The following is a description of a gene set: Human Gene Set: GOBP_INTRACELLULAR_TRANSPORT The directed movement of substances within a cell. studied in species Homo sapiens, and this is the list of marker genes: OSBP, TMED2, DOP1B, TUBA1B, PARK7, SEC63, LEPROT, KLC3, AP1G1, RAB1B, TBC1D10A, KIF28P, RILPL1, AHCYL1, ABRA, HGSNAT, SNX10, AP1S2, NOTCH1, DDX25, PPP6C, AHCTF1, BAG3, PKIG, EPS15L1, AP3B1, DTNBP1, PLA2G4E, RSRC1, IFT74, VIPAS39, PKD1, RGPD5, XPO5, ABCA12, HIF1A, SEC16B, STX1A, STX7, RUFY1, ACAP2, UPF1, NMD3, MIA3, TRAM1L1, REPS1, RAB8B, HPS1, MIA2, ZC3H11C, CSNK1D, NEFL, CCDC88C, BLOC1S2, MAPK14, FUZ, TRIM37, TNPO3, RILP, NDFIP2, HDAC6, HSPA9, TIMM10, CMTM6, CCDC186, MVB12A, OPA1, TRARG1, TOMM40, SNX18, DDX39A, VPS18, BLOC1S5, TNPO2, APPL1, E2F3, ATP2A3, ARFIP2, MDM2, ING1, SLC17A9, PCID2, TSG101, TOMM20, PPP3R1 (NCBI Gene Id 5534), REEP6, GRPEL1, ITSN2, ANKRD27, GAK, RAPGEF3, RGPD1, PRKAG1, KPNA2, SLC25A20, RAB11A, KIF20B, IL33, CRYAA, MICALL2, KIF1B (kinesin family member 1B), CRYAB, ATF2, YWHAB, ARL5A, SEC24D, CUL3, TMEM97, NUP153, KIF5B, NEDD4, STRADB, CRACR2A, CD74, TRAM1, ROMO1, STX10, SIRT6 (NCBI Gene Id 51548), SORCS2, SEC23B, MAPK15, PHETA1, RAB5B, TMCO6, MAP6D1, GLE1, TMEM53, SCG5, UFM1, SEM1, LAMP2, PEX7, FMN2, COPA, DOP1A, NME7 (NME/NM23 family member 7), MAGOH, SEC61G (SEC61 translocon subunit gamma), RHOB, WASH3P, XPOT, BICDL2, CTDSPL2, ARHGAP44, RIMS2, ATP9A, BRSK2, SCFD1, PRP4K (pre-mRNA processing factor kinase PRP4K), P4HB, TIMM21, SPAG17, WDR19, MAPT, SVIP (small VCP interacting protein), RNF126, BET1L, NXF3, FAM76B, GGA1, COPG2, LAMTOR1, STBD1, C12orf50, PHAX, STK4, IFT70A, RAB14, SEC24B, NCBP1, SCFD2, KCNQ3, CLTC, NDUFA13, MIR17, ASPH, CLEC16A, CLTCL1, HGS, VPS37C, CCDC38, RGPD4, SUFU, OAZ1, PTPN14, MX2, LMAN2L, BLOC1S1, TBC1D14, GRAMD1C, ATP6AP1 (ATPase H+ transporting accessory protein 1), OSBPL2, PLA2G3, TRAK2, TIMM17B, MYO19, PEX10, UBAC2, DTX3L, EHD3, NAPG, PLEKHF2, TENM1, BORCS8, B3GAT3, SMAD3, SNX1, PHETA2, TMCC1, DRD1, IFT20, YKT6 (YKT6 v-SNARE homolog), TERT, ARHGAP8, KIF3B, DENND10, SEC22B, IWS1, CLBA1, LIPA, PPP1CC, BECN1, RAB12, SNX12, ANKFY1, RAB28, AP1AR, RIOK2, ATP2A2, LCA5L, CPSF6, AP1M1, SNX11, EIF6, NAPB, PIK3R2, CHMP4C, TOMM22, AP5B1, SNX7, BARD1, EPS15, ZC3H11A, PEX3, SNX8, IFT56, STXBP2, PIP4K2A, STX19, EIF4ENIF1, SSX2IP, MIR185, TRAPPC6B, AP4B1, TRAPPC8, IFT80, NUP35, NETO1, SLC66A2, HERC2, ERGIC1, HTATIP2, RANBP3L, NPM1, FHIP1B, UPF2, WDPCP, MICALL1, UBE2G2, CITED1, AKIRIN2, RAB3GAP2, RBM22, STX16, TIMM8A, VPS37D, HYOU1, NGFR, WIPF3, SCAP, RASGRP1, ATP13A2, SYTL3, NTN1, XPO1, TRAPPC6A, NUP54, SNX2, LMF1, TMEM50B, CSE1L, AFTPH, GRIP1, ARL4D, ANXA8L1, THOC3, TMED6, RUFY3, BTBD8, NAPA, TBC1D23, MAP1A, CTTN, POM121L2, WAS, MYO5B, ZIC1, SRP54, ARFRP1, RHBDD1, EHD4, UMOD, PEX1, ANP32B, CLU, SNX30, BECN2, RGPD3, TTC21A, BIN1, TRIM23, PIKFYVE, MAP1B, KPNA5, IFT25, NOL6, CES1, ANKRD50, MREG, SORT1 (NCBI Gene Id 6272), VPS26B, BMP4, RAB7A, ARL5C, RAN, CHMP6, RAB2A (RAB2A, member RAS oncogene family), GRIPAP1, AP3M2, SCARB2 (scavenger receptor class B member 2), SPG7, RAB9B, HEATR5B, SPG11, GOLT1B, TMEM106B (NCBI Gene Id 54664), BLOC1S6, TMEM129, RAMP2, PIK3R1, TECPR2, RAB6C, NUP62CL, CNIH4, IPO4, NEFH, TRAPPC13, RAB4B, SMG5, SPIRE2, NFKBIA, VAMP3, RFFL, ATL3, RNF139, POM121B, MYO6, FABP3, KIF3A, RAB6D, VPS35L, JAK2, KPNB1, DENND1A, RELCH, RAB31, MTX1 (NCBI Gene Id 4580), THOC6, VPS13B, SEC22C, ARSB, DENND2A, RAB22A, TSNARE1 (NCBI Gene Id 203062), COG7, RAB20, TUBB, INPP5F, TMEM41B, GSK3B, BBS12, TOMM6, STEEP1, VAMP4 (NCBI Gene Id 8674), MYO7A, SAR1B, STAM, SEC16A, VTI1A, EIF2D, WASF1, CPT1A, LEP, AP1S3, CABP1, SYK, APBA1, AGAP2, SEC31A, SYT7, OAZ3, HOOK3, UBE2J1, DNAJC19, ENY2, CTAGE15, KIF13A, STAU2, CDH1, RAB5A, UBE2I, SNX31, SYTL2, RAB41, RAB35, SYNE2, WDR11, RAB11FIP3, TMED5, FAM53A, CTSA, SLN, CREB3L2, HPS4, RBM15B, STX4, MYO10, RAMP3 (receptor activity modifying protein 3), DERL3, ARL6, MAPK8IP3, CRY2, CDKN1B, VPS45, CLN5, BAIAP3, AP2S1, KPNA7, STARD4, NXT1, NUP107, AKT1, PPM1A, SCYL2, GBF1, SERAC1, KIFC2, MED1, RGPD2, AKAP8L, NUTF2 (NCBI Gene Id 10204), GAS6, SGPP1, TIMM9, SOD1, RANGRF, CHP2, LRP1, ARL3, AGBL4, USE1, RPGR, YIF1A, HOOK1, BORCS7, USP7, NUP93, MVB12B, TIMM44, GOPC, ARFGAP3, KIF1C, SEH1L, TFG, ATG5, NUP62, FLOT2, DERL2, VPS11, CAMSAP3, TOMM7, HSPB1, LRRK2, DDX39B, CD36, FERMT1, DYNC1LI1, MAGEL2, NEMF, RABL3, TAP2, AP3M1, COPZ2, LMNB1, RABGGTB, NHERF1, SFN (NCBI Gene Id 2810), ARL5B, IFT140, SYNDIG1, FEZ1, CD63, TRIM46, SPAST, TUBA1A, F8A2 (coagulation factor VIII associated 2), SPRN, PIK3R4, AGK, DENND3, IFT70B, PCSK9, HIKESHI, UBAP1, UBXN6, DYNLT2B, ENTR1, CHMP7, OAZ2, SSNA1, TOMM5, AP5M1, PICALM, LONP2, BET1, TRAPPC4, TMED7, CHP1, MAP6, ARL8A, SDCBP2 (syndecan binding protein 2), MAP2, DYNC1I2, MIR27B, HSP90AA1, CCDC88B, SNX9, VAMP7, TMED10, HNRNPA2B1, YTHDC1, TBC1D13, F8A1, SRC, CDKN2A, CHMP1A, SNX13, COG3, ANP32CP, SPAG9, RAB10 (RAB10, member RAS oncogene family), RHOT2, ERC1, LDLR, SGSM2, IRGM, NAGPA, NUP210, ARHGAP21, SMO, RGPD8, ACTN4, CHMP3, DYNC2LI1, ACTR10 (actin related protein 10), PEX16 (peroxisomal biogenesis factor 16), AP5S1, WHAMM (NCBI Gene Id 123720), TBC1D10B, ARL11, PRKCD, ACTR2, PRR5L, NUP88, RANBP2, VPS28, SNF8, TBC1D17 (TBC1 domain family member 17), KIF17, NUS1, IFT22, TRAPPC11, CLTA, STAR, LRRC7, NDE1, UFD1, HEATR5A, PLEKHA8, RBM4, CLUAP1, MTCH1, ABCD1, SYT4, TMED3, INTU, SCP2, PLEKHM1, THOC2, FNBP1L, LARGE1, ASPSCR1, NUP214, RIC1, TSPO2, AP4E1, MAP2K2, SYS1, MAPK3, HSPA12A, TRAPPC9, VPS50, RANBP3, NUP42, KIF16B, APPL2, CORO1A, MDN1, LAPTM5, CILK1, PREPL, KIF5A, KIFBP (kinesin family binding protein), ECT2, PCDHGA3, VPS33B, TERF2, NOP9, ARMCX3, MAP1LC3C, SLC48A1, NPLOC4, STXBP3, WDR81, LRPPRC, PLN, VCP, WASHC4, ADRB2, RIMS1 (regulating synaptic membrane exocytosis 1), RAB18, LMNB2, AGFG1, MYLK2, CCDC91, CRYZL2P-SEC16B, MAP1S, PEX5, ITSN1, SH3TC2, TRIM27 (tripartite motif containing 27), STX17, LMTK2, VPS41, SPTBN5, NUP205, VPS36, UBE2O, LYST (lysosomal trafficking regulator), ABCA2, KLHL12, TXNIP, BORCS5, PLEKHJ1, EHD2, PLEKHA3, CSPG5, SNX32, ABCG1, LZTS2, MYO1C, USO1, AP3B2, MPPE1, WDR91, COPZ1, SETD2, GOSR1, NUMA1, PML, CDC42, PREB, ARL8B, MGRN1, ZFYVE9, EIF4E, CCHCR1, AFG2B, BICD2, BICDL1, TMEM30B, MON1A, EDEM1, IFT46, BORCS6 (BLOC-1 related complex subunit 6), YIF1B, TMEM201, FBXO22, DENND1C (DENN domain containing 1C), GRAMD1B, ANKLE1, TMEM30A, BBS5, TLK1, VPS26C, TMEM87B, MYH10, SRSF3, RABL2B, AKAP5, CCDC22, C2CD5, THOC7, ERLEC1, AUP1, EHD1, RAB43 (NCBI Gene Id 339122), DCLK1, SYTL1, PEX2, SHH, SEC23IP, C9orf72, SIX2, BICD1, MRLN, EP300, WASHC2A, GGA2, ATG16L1, DST, EEA1, SEC24A, FMR1, ARF3, AP2B1, TMED9, IFT52, C17orf75, STRIT1, MAGOHB (NCBI Gene Id 55110), STK11, SNX6, NDRG4, PEX6, CEP120, CTAGE4, SEC13 (NCBI Gene Id 6396), CWH43, RHOBTB3, TANC2, THOC5, IPO13 (importin 13), LAMP1, SRSF10, RABL2A, ALMS1, PABPN1, GLI3, IFT43 (intraflagellar transport 43), VPS8, SYBU, ZC3H11B, RAB27B, MTMR2, RAB1A, GCC2, MTMR4, STK3 (serine/threonine kinase 3), ATXN1, RIPOR1, RAB24, YWHAH, KPNA1, DNAJC27, ANXA8, RAB32, BLTP3B, ERP29 (endoplasmic reticulum protein 29), TRAPPC5, SIRT7, ZMPSTE24, DHX9, ALS2CL, NF1, DCTN1, TIMM13, TIMM10B, ARL17B, NR4A1, DAB2, SLU7, VPS53, RAB11FIP4, PHB2, CHMP2B, SYTL5, NF2 (NF2, moesin-ezrin-radixin like (MERLIN) tumor suppressor), STAT3, JUP, DERL1, IGF2R, STX2, MAVS, LYSET, NXT2, RCSD1 (NCBI Gene Id 92241), DLG2, AP2M1, HNRNPA1, RAB7B, ARCN1, WASHC5, TGFB1, TUB, POLDIP3, TACC2, SNX33, GOLGA2, EDEM2, SNX27, IPO11 (NCBI Gene Id 51194), FYCO1, RAB5C, BCAP29, HYAL2, KIF1A, PSAP, NDFIP1, NEAT1, OS9, ANK1, F8A3 (coagulation factor VIII associated 3), TSC2, CDK5, WASH6P, STX1B, UBR5, MFSD1, BCAP31, DYNC2I1, TIMM8B, NUP98, NUP188, TNPO1, SEC61A2, SEPTIN8, VAMP2, KPNA3, KLHL20, TRAPPC2B, VPS51, ZFAND2B, PKIA, DYNC2H1, RANGAP1, TOMM20L, SFPQ, STX11, SYNRG, ARV1 (ARV1 homolog, fatty acid homeostasis modulator), NSG2, DNAJC6, DYNC2I2 (NCBI Gene Id 89891), COPB1, CDAN1, PICK1, CASC3, MGARP, EVI5, ACD, XBP1, PEX12, RGP1, SEC22A, ERO1B, TMED1, SLC30A2, AP2A2, ADAR (adenosine deaminase RNA specific), LTV1, RAB6A, ANP32A, STX18, VPS35, SIL1, INSIG1, AP3D1, MAP2K1, SLC30A3, YIPF5, SLC51B, VPS52, WDR35, NPC1, SEC23A, TRAK1, HHEX, IFT122, XPO6 (NCBI Gene Id 23214), GFAP, EMP2, PEX5L (peroxisomal biogenesis factor 5 like), SUN2, YOD1, SCRIB, EXPH5, SLIT1, NCBP3, CAPN10, KPNA4, ERGIC3, TOMM70, KIF5C, TPCN2, IFT27 (intraflagellar transport 27), APOD, MCM3AP, TRAF3IP2, LMAN1, RANBP1, BCR, ARF5, ATL2, STX12, SORL1, TRIP11, NPAP1, PLEKHF1, ABCA1, XPO7, TRAPPC2L, TRMT10B, PEX26, PCNT, CHML, FAM53B, TAP1, SRPRA, AP5Z1, AKTIP, GRIP2, VTA1, GNAS, LEPROTL1, COPG1, APP, HSP90B1, HM13, UEVLD, NDEL1, CPT1B, TUBA1C, HEATR3, ARL14, WASL, ZPR1, GNPTG, RGPD6, RFTN1, CHTOP, HAP1, MKKS, FRAT1, STAM2, EIPR1, UNC93B1, MTCH2, SNX3, TINAGL1, ARFIP1, ALYREF, EI24, SNX4, CLMN, CHMP2A, ALKBH5, WASHC1, TBC1D20, WLS, IPO9, CLTB, IFT172, CHMP4A, DYNC1H1, SNX5, TXN, NUP50, KIFAP3, EPM2A, AP3S2, STX6, TRAPPC3L, PDCD6, NUDC, SIX3, ERGIC2, MBTPS1, RAMP1, WNK1, CHMP1B, YIPF6, TGFBRAP1, M6PR, NRDE2, AAAS, XPO4, TRAPPC3, DDX19A, CDR2L, HSBP1, CTAGE8, RAB11B, COMMD1, ATP6V0D1, TACC1, MON2, GGA3, EMD (NCBI Gene Id 2010), YIPF4, TIMM50, CLN3, HSPA8 (NCBI Gene Id 3312), PPFIA2 (PTPRF interacting protein alpha 2), SAR1A, FYTTD1, STAU1, VPS13D, TP53, BBS7, RAB23, HPS5 (HPS5 biogenesis of lysosomal organelles complex 2 subunit 2), NCBP2, GOSR2, GAS1, HTT (huntingtin), RDX, ALS2, PEF1, RBM33, ABCD3, AP1G2, ZFAND1, CAMK1, NDP, RAB6B, ATG14, PPP3CA (protein phosphatase 3 catalytic subunit alpha), AP1B1, DOCK7, TRAPPC1, ACTN2, EIF4A3, IER3, UBB, IFT81, ARL4C, KIF21A, VPS37B, DENND1B, GNPTAB, MYO5A, AP2A1, ZC3H12A, FGF9, SNX17, MLPH, RGS14, PAFAH1B1, DENND5A, ATP6V0D2, TIMM22, SARNP, NUP160, SMG1, CCDC93, PTPN1, HPS6, PSEN1, DAW1, CD81, RABGGTA, TMEM87A, DIAPH3 (NCBI Gene Id 81624), RAB9A, CTAGE9, TRAPPC2, VPS4B, BLOC1S3, DDX19B, LCA5, PEX19 (peroxisomal biogenesis factor 19), LAPTM4B, SYVN1, RBSN, CHMP4BP1, RPH3AL, POM121C, USP9X, GPRASP1, PGAP1, RBM10 (RNA binding motif protein 10), TRAF3IP1, SDAD1, FAM53C, PRKD1, VAPB, WASHC2C, NUP155, VTI1B, PIK3C3, TMED4, RPL23 (NCBI Gene Id 9349), IPO8, CDX2, STRADA, GOLT1A (golgi transport 1A), TARDBP, IFT57, MYRIP, ARHGAP1, ARHGEF2, HMGXB4, SYNE3, FAF2, RAB38, NCOA4, IFNG, CBLB, WASHC3, COPE, STX5, POM121, LCP1, SEC61A1, KXD1, MDFIC, RASSF9, CFL1, UCHL1, CCDC88A, CEP131 (centrosomal protein 131), TM9SF4 (transmembrane 9 superfamily member 4), TRAPPC12, PINK1, RILPL2, DPY30, ELAVL1, PCM1, MTM1, IER3IP1, RPH3A, RAB13, VPS26A, PAM16, PLK3, RBM8A, RAB29, CTAGE6 (NCBI Gene Id 340307), LMNA, NUP85 (NCBI Gene Id 83705), CORO1C, VPS13A, TRAPPC10, RUFY4, UXT, NUP133, NPC2, YIPF7, DNAJC15, SP100, HSPA1A, IFI27, WWC1 (WW and C2 domain containing 1), NSF, SEC31B, PEX14, MON1B (MON1 homolog B, secretory trafficking associated), UHMK1, YWHAE, AP3S1, BACH2, AP4M1, SURF4, MYO1D, IPO5, HNRNPU, LSG1, TRIM28, GCKR, VPS16, CHMP4B, TIMM17A, REEP5, PPP1R10, TIMM29, HSPA5 (NCBI Gene Id 3309), ABCD2, PRICKLE1, DESI1 (NCBI Gene Id 91610), SUMO1, AGTPBP1, RABGEF1 (NCBI Gene Id 27342), LMAN1L, CEP290, HPS3, IFT88, MTX2, RAB21, TRIM58, NRBP1, RHOT1, SNX15, IPO7, SSB, ICE1, DNAJC13, STXBP1, EPG5, TOM1, SMG7, SNX16, PEX13, THOC1 (NCBI Gene Id 9984), KHDRBS1, ZFYVE16, SNUPN, AXIN1, ANKRD54, CALR, ARF4, MSN, REEP2, CPT2, AP1M2, SEL1L, TACC3, SAMM50, NUP43, KPNA6, GRN, RANBP17, NXF5 (nuclear RNA export factor 5), RINT1, TBC1D10C, VPS54, STX8, CHM, SPAG5, SLC30A4, KIF4A, MLC1, EXOC6B, SQSTM1, RAB1C, MAK, VAPA, CDK1, ARL1, NXF2B, RPS15, GLP1R, HDAC3, HERPUD1, PTPN11, LMAN2, PTTG1IP, RPAIN, AP1S1, TBC1D5, VPS39, RAB17, MYBPC3, ATP2A1, RITA1, TMEM230, VPS37A, TMEM94, EXOC6, EFCAB7, SPIRE1, POLA2 (DNA polymerase alpha 2, accessory subunit), ZDHHC2, ARL4A, RANBP6, SMURF1, SLC35D3, TRAM2 (translocation associated membrane protein 2), DYNLL1, ANGPT1, NDC1, WIPI1, CORO7, TIMM23, CIDEB, MMP12, LDLRAP1, ADIPOQ, COPB2, NSG1, RAB19, SEC61B, RAB8A, NSUN2, ARF1, VPS13C, CERT1, SNAPIN, BCL3, TTC21B, CLIP3, FHOD1, REPS2, RAE1, TMEM108, APPBP2, BLTP1, HCLS1, DYNC1I1, EZR, FBXW11, HOOK2, ZW10, SEC24C (NCBI Gene Id 9632), ABCD4, VPS33A, SUN1 (Sad1 and UNC84 domain containing 1), IL1B, NXF2, BLOC1S4 (biogenesis of lysosomal organelles complex 1 subunit 4), TNNC1, CTAGE1, GPIHBP1, TMEM50A, SELENOS, NUP58, RTN2, VPS4A, FLNA, MAPK1, MALT1, PTPN23, CD24, STX3, SEC62, NUP37, VPS25, PURA, DMAP1, CALY, ARF6, NXF1, APOE (NCBI Gene Id 99), ANXA2, SYTL4, ATP1B1, EGR2, ANXA2P2, PDCD10, GRAMD1A, CDKN1A (cyclin dependent kinase inhibitor 1A), FRAT2, TEX261, TPR, PRKACA, SMG6, PRKN, FAM91A1, CHRM1 (cholinergic receptor muscarinic 1), GRPEL2, CHMP5, PPP1R12A, FCHSD1, VPS29, TMEM167A, BVES